Given this list of marker genes HMGCS1, SARDH, MTFR1, FGB, PCLO, SLC22A23 (solute carrier family 22 member 23), PLXNB3, SPX, CCDC192, MLIP, NEXN, MIR539, PABPC5, IGSF21, PMFBP1, LMX1A, LZTR1, CBX1, FSTL5, CRACR2B, FANK1, FAM3A, ATP6V0D1, MARCHF1, PRLH, SRY, DMAC2, TNFRSF11B, BMP2, EMCN, VNN1, MIR222, C1orf185, HACD2 (3-hydroxyacyl-CoA dehydratase 2), SLC25A11, ETS2 (NCBI Gene Id 2114), NPY2R, TMIE, RUBCNL, TRIM31, RBM28 (RNA binding motif protein 28), TMC5 (NCBI Gene Id 79838), TMEM82, TPTE, SMYD4, SIAE, SPDYE4, SPRR3, IDH1, DRD3, MMP12, DNASE2B, RPRD1B, EPPK1 (epiplakin 1), PPP1R14B, ERICH6B, FAM117A, IFT43, ACTA2, NOS3, GLB1L2, ADAMTS7, KCNQ4, SLC22A5, CCDC141, KIT, NRBP2, NKG7, NPNT, HMBS, ADGRF5, CMKLR1, CIMIP5, SAP30BP, RETN, CD109, SPICE1, ELAPOR2, A3GALT2, NEK4, JPH1, FAAH, HTR7 (5-hydroxytryptamine receptor 7), RNF114, NELL2, KRT76, ELOVL5 (NCBI Gene Id 60481), NEXMIF, LBR, METTL21A, RGS14, FBXO46, FOXO3, LGR4, MIR532, FABP7, RER1, TMEM38B, NEUROD1, TOR1B, SHC3, IDO2, PEG10, SHOC1, IL31RA, EIF4E1B, PPFIBP2, PMP2 (NCBI Gene Id 5375), ZFP30, VNN3P, SNX4, IFTAP, ME1, LPAR4, PAF1, RSPO2, MINAR1, GFAP, DIP2C, ADARB2, XYLB, SDHA, SGMS1-AS1, CCM2L, IGFLR1, SERPINI2, MACROH2A2, COL11A2, SLC6A5, MSR1, CASP12, PSPH, SPATA7, RCVRN, NCKAP1L, C2orf80, TSPO2, TRPA1, MAT1A, C2orf69, HOOK1, BPIFB1, ELF5, PDE10A, ACTR2 (actin related protein 2), here is a description of the gene set: Human Gene Set: GSE14413_UNSTIM_VS_IFNB_STIM_RAW264_CELLS_UP studied in species Homo sapiens Genes up-regulated in RAW264.7 cells (macrophage): control versus stimulated with IFN-b. Cytoplasmic DNA triggers the activation of the innate immune system. While downstream signaling components have been characterized, the DNA sensing components remain largely elusive. We performed a systematic proteomics screen for proteins that associate with DNA, traversed to a screen for IFN-β-induced transcripts. We identified DSIRE (DNA sensor for the IL-1β response, previously called AIM2) as a candidate cytoplasmic sensor. DSIRE showed a marked selectivity for double-stranded DNA. DSIRE can recruit the inflammasome adaptor ASC and gets redistributed to ASC speckles upon coexpression of ASC. RNAi-mediated reduction of DSIRE expression led to an impairment in IL-1β maturation. Reconstitution of unresponsive cells with DSIRE, ASC, caspase 1 and IL-1β showed that DSIRE is sufficient for inflammasome activation. Overall, our data strongly suggest that DSIRE is a cytoplasmic DNA sensor for the inflammasome. from publication Bürckstümmer T, Baumann C, Blüml S, Dixit E, Dürnberger G, Jahn H, Planyavsky M, Bilban M, Colinge J, Bennett KL, Superti-Furga G (PMID 19158679)